Given this list of marker genes RPL23AP27, SULT1C2, RGPD4-AS1, ENSG00000234162, IL1RL1, SLC9A2, SMIM12P1, IL18R1, RPL22P10, ANAPC1P6, ENSG00000298919, LINC01594, LINC01103, LINC01886, SULT1C4, ENSG00000236109, TGFBRAP1-AS1, RPS21P2, IL1RL2, WASF1P1, LIMS1-AS1, RPL22P8, SRSF3P5, HMGB3P11, SDR42E1P5, IL18RAP, LINC01159, LINC01796, CAPZBP1, TGFBRAP1, SLC5A7, MRPS9-AS2, LIMS1, FHL2, ILRUNP1, LINC02946, PANTR1, PPP1R2P5, UXS1, LINC01935, GMCL1P2, SRSF3P4, GPR45, C2orf49, SNORA72, LINC01885, ENSG00000227157, LINC01102, GCC2-AS1, RGPD4, ST6GAL2, CFAP144P2, SETD6P1, SLC9A4, CD8B2, LINC01789, ECRG4, RGPD3, LINC01831, PLGLA, RPL27AP4 (NCBI Gene Id 100271299), GCC2, CRLF3P1, SULT1C2P2, IL1R1-AS1, MRPS9, SULT1C5P, EEF1A1P12, SULT1C3, MFSD9, LINC01965, LINC01918, C2orf49-DT, MRPS9-AS1, NCK2, GACAT1 (NCBI Gene Id 104326057), TMEM182, ACTP1, AHCYP3, MIR4772, POU3F3, ST6GAL2-IT1, LINC01593, here is a description of the gene set: species: Homo sapiens Human Gene Set: chr2q12